The following is a description of a gene set: A structure involved in coupling stereocilia to one another in sensory hair cells There are four morphologically distinct types: tip links, horizontal top connectors, shaft connectors and ankle links. Tip links and horizontal top connectors are the only inter-stereocilia links associated with mature cochlea, whereas ankle links appear during development of the auditory hair bundle. Mouse Gene Set: GOCC_STEREOCILIA_COUPLING_LINK species: Mus musculus, and this is the list of marker genes: Vezt, Diaph3, Myo7a, Ush1c, Ush2a, Pdzd7 (NCBI Gene Id 435601), Whrn, Adgrv1